The following is a description of a gene set: species: Homo sapiens Human Gene Set: HAY_BONE_MARROW_CD34_POS_HSC from publication Hay SB, Ferchen K, Chetal K, Grimes HL, Salomonis N (PMID 30243574), and this is the list of marker genes: BST2, CYYR1, BEX2, RSL1D1, GSTM5, KRT8 (keratin 8), BMAL2-AS1, EBPL, ZFAS1, RPL26, SLC8A3, FAM133A, ZNF521, GCSAML, WASIR2, HOXA7, HOXB5, PRKG2, HOXA10-AS, TMEM163, DSG2, MYCNOS, NPR3 (NCBI Gene Id 79614), LAPTM4B, ARMCX1, EMCN, ELMO1, ATP1B1 (NCBI Gene Id 481), CCDC42, C9orf43, HOXA9, HLF (NCBI Gene Id 3131), ADGRG6, IQSEC3-AS2, LINC02983, FAM30A, CHRM3 (cholinergic receptor muscarinic 3), PROM1, EIF3L, HOXB6, PLOD2 (NCBI Gene Id 5352), TAOK3, LNCEGFL7OS, CBX2, TCEAL4, DLK1, CCNB1IP1, SULT1C4, DYNLT5, EPCAM-DT, HMGA2, CASC15, LINC01122, EGFL7, FGD5, BTF3, LINC03073, ENSG00000229425, PCDH17, TLCD5, SLC1A6, HOXA10, NKX2-3, GNAI1, TAF1D (NCBI Gene Id 79101), LINC02573, FBXW9, CLEC9A, HINT1, ITGB8-AS1, SPOCK3, H2AC25, NKAIN2, RBPMS, DPPA4, BAALC-AS2, HOXB-AS3, CCDC171, UCHL1, CYTL1, IL18, IL12A-AS1, ZBTB8A, RACK1, RPS9, HOXB3, BEX4, RPL15, CALN1, BAALC, CRHBP, SNX10-AS1, MFAP2, NRIP1, CCDC175, UBR5-DT, HTR1F, RPS24, NYNRIN (NYN domain and retroviral integrase containing), ATP2C1, SAMD13, HOXA3, ITGA9, RASSF9, CTSF, BEX1, HOXA6, ROBO4, CD34, MYCT1 (MYC target 1), MIR1915HG, PCBD1, C3orf80, AVP, NPM2, EIF3D, AVPR1B-DT, CRYGD, KRT18, SYPL1, EEF2, CD164, MECOM, MSRB3 (NCBI Gene Id 253827), PRDM16-DT, EPB41L4A-AS1, BSPRY, GUCY1A1, EHD2, NAP1L3, CDH7, TCEAL2, NACA (nascent polypeptide associated complex subunit alpha), NPDC1